Given this list of marker genes KRT14, POLR3A, TCIRG1, ITGB4, CDH11, EDAR, SLC35C1, CAT, C1R, FIG4, ALPL, CYP27A1, CLPB (ClpB family mitochondrial disaggregase), ZMPSTE24 (NCBI Gene Id 10269), FERMT1, DKC1 (dyskerin pseudouridine synthase 1), CSTB, RUNX2, WNT10A, COL3A1 (collagen type III alpha 1 chain), FOSL2, PLEKHM1, CLCN7, SNX10, VDR, TNFRSF11B, ELANE, EDARADD, TNFRSF11A, GFI1, KDF1, SASH1, NTRK1, TINF2, TP63, RSPO1, SH3PXD2B, SEC23A, RPS6KA3, C1S, CTSC, PRKD1, LRP4, TERC, MIA3, VAC14, TERT, SRP19, PARN, LMNA, NOTCH2, PIGT, GJA1, RBM28, TNFSF11, ERCC4, AEBP1, TRAF6, here is a description of the gene set: Premature loss of teeth Human Gene Set: HP_PREMATURE_LOSS_OF_TEETH Exfoliation of a tooth more than 2 SD earlier than the normal age for the deciduous teeth and not related to traume or neglect. Exfoliation of a permanent tooth is per se abnormal. studied in species Homo sapiens